The following is a description of a gene set: Genes up-regulated in comparison of dendritic cells (DC) stimulated with LPS (TLR4 agonist) at 24 h versus DC cells stimulated with poly(I:C) (TLR3 agonist) at 24 h. species: Homo sapiens from publication Amit I, Garber M, Chevrier N, Leite AP, Donner Y, Eisenhaure T, Guttman M, Grenier JK, Li W, Zuk O, Schubert LA, Birditt B, Shay T, Goren A, Zhang X, Smith Z, Deering R, McDonald RC, Cabili M, Bernstein BE, Rinn JL, Meissner A, Root DE, Hacohen N, Regev A (PMID 19729616) mouse primary BMDCs were stimulated with tlr ligands and gene expression changes were profiled on Affymetrix arrays Human Gene Set: GSE17721_LPS_VS_POLYIC_24H_BMDC_UP, and this is the list of marker genes: UQCRFS1, SLC28A3, EMC10, NUCB1, SERPINE2, FASTKD2, WAS, GSTO1, GNL2, TFRC, RBMXL1, NR4A2, SUGP2 (SURP and G-patch domain containing 2), CA2 (carbonic anhydrase 2), HOPX, PAFAH2, IPO9, SNRNP25, NIP7, WRNIP1, DDT, CLDN6, SEC61G, TRPT1, TTC5, PGM1, PITX3, CAT, SLC7A11, COQ4, ATPAF2, SLC35A1 (NCBI Gene Id 10559), GMFG, TNF, GBE1, PPP3CC, MAD2L2, TMEM165, UFM1, NIT1, NUDT2, NNT, JAGN1, RAB10, ABT1 (activator of basal transcription 1), CIAO1, MAGOH, GPR84, CYB5A, IL36G, COPRS, NDP, MFSD8, PACRGL, TXNL1, YWHAQ, SWI5, TPRKB, METTL22, GTPBP4, ECI2, CARMIL1, MRPS18A, MAD2L1, C16orf87, RIOX2, BHLHE40, RAB14, UTP4 (UTP4 small subunit processome component), SDHAF1, HAS3, EBP, SCAMP1, NUP160, PFKFB1, IL10, ENTREP3, ACO1, ZIC5, RBM19, PI4K2B, IL1RAP, MBNL3, PRAF2, VTA1, EREG, DERL2, PPM1B, KIAA1143, GLRX3, ALYREF, DNAJC19, HIBCH, RPP14, CSDE1, HSD3B7, ABRACL, GSTT2, TMED4, CCT4, FKBPL, FTL, APBB2, RSL24D1, CIAO2B, PER2, FANCC, RRP9, GSS, EIF3I, B4GALT1, RAB23, HDGF, PLPP3, RAD17, PKIG, SLC20A1, MFSD14B, IAH1, MOB4, PSMD12, TMEM126A, DVL1, NSD1, NIF3L1, CLMP, TRMT112 (tRNA methyltransferase activator subunit 11-2), APP, GFER, EBNA1BP2, CIBAR1, DYNLRB1, IER3 (immediate early response 3), CDC25A, CHD1L, IDE, DAP3, UBXN10, VPS41, DNAJB6, PDE10A, KPNA2, PFKL, POLR2G, RDH10, PCBD2, HDHD5, E2F6, PUM3, SLC22A4, EXOSC10, CYP4F12, NAA10, EEFSEC, KICS2, MT1E, ZMPSTE24, TM9SF4, PNPLA8, GLOD4, CDC26, DOCK7, IGFBP4, NDUFB2, NRBF2, MRPS18B, BLMH, NOL11, ATP5F1D, PHPT1, FAH, NUTF2, YBX1, SMIM30, PTCH1, ALCAM, AFG1L, FTSJ1, TTC39C, BST1, ACY3, SLC25A30, STIP1 (NCBI Gene Id 10963), DVL2, ICOSLG, BRAF, TMEM63B, LPCAT3, CYB561D2, MFSD1, SNRNP27, PFDN6, MTURN, PRMT3, EMILIN1, FAM8A1, WBP2, FAM174A, UBA2